The following is a description of a gene set: Any process that modulates the frequency, rate or extent of the circadian sleep/wake cycle. Mouse Gene Set: GOBP_REGULATION_OF_CIRCADIAN_SLEEP_WAKE_CYCLE studied in species Mus musculus, and this is the list of marker genes: Ptger3, Ghrl, Adora2a, Nr1d1, Nps, Parp1, Ada, Ptgds, Alb, Ptger4, Pmch, Adora1, Il6, Csf2, Adrb1, Nmu, Mtnr1b, Ghrh, Ghrhr, Drd2, Fxr1, Kcna2, Npy2r (neuropeptide Y receptor Y2), Drd3, Per3 (period circadian clock 3), Hcrtr2, Uts2r, Uts2, Casp1, Cort, Chrnb2, Drd1, Nlgn1